The following is a description of a gene set: The lipid bilayer surrounding an endocytic vesicle. studied in species Mus musculus Mouse Gene Set: GOCC_ENDOCYTIC_VESICLE_MEMBRANE, and this is the list of marker genes: Rab38, Ston1, Inpp5b, Mtmr4, Tlr2, H2-Q10, Tapbp, H2-K1, Slc11a1, Dnm2, Rab43, Rab32 (RAB32, member RAS oncogene family), Ap2a1, Csf3r, Anxa3, Cubn, Rab7b, H2-Q7, Mcoln1, Dmbt1, Pip4p2, Lamp1, Pikfyve, Pip4p1, Pfpl, Rab11fip3, Rapgef1, Scara5, Sgip1, Slc15a2, Irgm1, Scarb2, Sec61a1, Tcirg1, Rab11b, Rab11a, H2-D1, H2-T23, Lamp2, Ston2, Hvcn1, H2-T3, Coro1a, Tlr1, Rab9b, Ap2b1, Ap2m1, Snap91, Tyrp1, Rab8b, Smo, Mpeg1, Dync1li1, B2m, Rab8a, Tbc1d5, Btbd8, Rab34, Rab7, Syt7, Rab11fip1, Ocrl, Appl2, Slc9a9, Slc48a1, Ap2a2, Tlr6, Rab20, Rab5a, Slc18a3, Rab10, Eps15, Ap2s1, Rab31, Rab9, Epn2, Rab23, Rab22a, Tap1, Clec4e, Rab39, Rilp